Given this list of marker genes Dut, Cda, Uck1, Upp1, Dck, Tbpl1, Nme2, Dhodh, Uckl1, Ctps1, Uprt, Ak9, Nme3, Dhfr, Cad, Nme5, Upp2, Shmt2, Slc4a7, Shmt1, Nme4 (NME/NM23 nucleoside diphosphate kinase 4), Uck2, Dctd, Tyms, Nme7, Ctps2, Cmpk1, Umps, Dtymk, Nme1, Nme6, Cmpk2, here is a description of the gene set: Mouse Gene Set: GOBP_PYRIMIDINE_NUCLEOTIDE_BIOSYNTHETIC_PROCESS studied in species Mus musculus The chemical reactions and pathways resulting in the formation of a pyrimidine nucleotide, a compound consisting of nucleoside (a pyrimidine base linked to a deoxyribose or ribose sugar) esterified with a phosphate group at either the 3' or 5'-hydroxyl group of the sugar.